Given this list of marker genes SMAP1, PDE12, PTGER4, MINAR1, AGFG1, ETNK1, MAPK13, APOA5, NANP, LANCL1, TLL1, TRPS1, MBD5, KLF12, ATP6V1G3, SHH, VDAC2, TSHZ1, PRMT2, ZFHX3, ZBTB33, GRK3, SFPQ, SESN3, LTBP3, TM9SF3, PPP4R3A, SBF2, TWF1, NNT, KBTBD2, IKBIP, CLEC2D, RCN2, DTNA, SAMD5, RC3H1, TMPRSS11E, POU4F2, TMEM209, INO80D, HDAC9, MAT2B, DLGAP1, TRIM23, LACTB, GABRA5, PTF1A, CDC123, EPHA4, SMIM17 (NCBI Gene Id 147670), SLC24A2, GJB2, ZNF326, NPAT, ZNF385B, PSIP1, STAT3, ASPA, BECN1, LCA5, SEPSECS, TAB3, ZXDA, TBR1, PRDM5, VASH2, NUCKS1, SOWAHA, HIPK2, AZIN1, RNF19A, KIAA0232, SATB1, SLC7A14 (solute carrier family 7 member 14), PIK3R1, AFF4, NUDT12, PPM1E, ZCCHC10, PCDH9, LSM11, PELI1, SLC39A9, ALKBH8, PCF11, JAGN1, EPHA7, TLE1, USO1, ITCH, RPS6KB1, TPTE, RAP2B, ZNF12, BCL11A, TP53RK, PATZ1, ZNF568, HPDL, ZNF529, TRIL, ARHGAP44, BRWD3 (bromodomain and WD repeat domain containing 3), CREBRF, METTL15, ESYT2, ARGFX, RBM41, PLCB1, ENSA, PDE1C, CASP10, ABCA8, PTGR2, RXFP2, SV2C, ATP11C, PALS2, ARID2, KIAA2013, PIK3C2B, SLIT3, LIX1L, PPFIA2, BTAF1, FLI1, CLASP2 (NCBI Gene Id 440948), CAPS2, ZFHX4, E2F6, ZDHHC21, LPAR1, METTL8, TRIP11, RAP1A, BCL2L13, DAB1, USP33, PDE6D, CTNND2, MICU3 (mitochondrial calcium uptake family member 3), RAB14, CAMTA1, FOXO3, AAMDC, GPR137B (NCBI Gene Id 7107), TBL1X, AGGF1, DCX, ENTPD7, PLEKHA2, MEF2C (myocyte enhancer factor 2C), OPRM1, SPINT2, SLAMF6, DUSP10, CADM2, ZNF260, ANKRD28, USP13, SLC35G1, FCMR, FGFR3, ZBTB44, KCNE3, STK4, ERI1, UBTD2, SLC38A1, here is a description of the gene set: Genes predicted to be targets of miRBase v22 microRNA hsa-miR-138-2-3p in miRDB v6.0 with MirTarget v4 prediction scores > 80 (high confidence targets). species: Homo sapiens Human Gene Set: MIR138_2_3P from publication Chen Y, Wang X (PMID 31504780)